Given this list of marker genes 4930599N23Rik, Trbv14, Gm2189, Mir490, Cnot4, Ptn, Tmem178b, Trbj2-6 (NCBI Gene Id 100125260), Trbv28, Gm15697, Trbv5, Mkrn1, Trbv12-1, Trbj2-5, Gm13861, Gm2719, 1700065J11Rik, Svopl, Gm25402, Fth-ps2, 1700111E14Rik, Trbj1-4, Trbv12-2, Zc3hav1l, Trbv13-1, Trbv21, Trbv26, Akr1d1, Rpl30-ps1, Braf, Hipk2, Bpgm, Gm29813, Try10, Tas2r108 (NCBI Gene Id 57253), Trbj1-3, Gm23010, Trim24, Trbv13-3, Mtpn, Gm2663, Clec5a, Gm18964, Ybx1-ps2, Rab19, Tmem213, Gm5409, Nup205, Cald1, Or9a4, Tas2r137, Trbv17, Slc37a3, Luc7l2 (NCBI Gene Id 75005), Tbxas1, Trbv11 (T cell receptor beta variable 11), Gm7452, Gm13858, Trbj1-7, Ssbp1, Klrg2, Gm4744, Fam180a, Trbj1-6, Trbv20, Wdr91, Trbv22, Creb3l2, Akr1b8, Stmp1, Trbv12-3, Trbj2-2, Atp6v0a4, Trbv4, Akr1b10, Trbd2, Trbv30, Trbv29, Gm13857, Prss3, Trbv8, D630045J12Rik, Prss2 (serine protease 2), Mrps33, Agk, Moxd2, Trbj1-2, Or9a7, Trbv18, Ubn2, Gm7463, Trbv15, Trbj2-4, Dgki, 1810009J06Rik, Prss1, Prss1l, Trbv27, Trbv25, 9330158H04Rik, Slc23a4, Trbv6, Ift56, Gm10244, Gm7554 (NCBI Gene Id 676634), Akr1b1, Trbv13-2, Trbc1, Trbj2-3, Trbv7, Clec2l, Fmc1, Npn2, Trbj1-5, Trbv9 (T cell receptor beta variable 9), Trbv31, Trbv16, Prss3l, Prss3b, Trbv3, Trbv19, Prss59, Gm7492, Wee2, Gm23273, Kdm7a, Stra8, 1700025N23Rik, Akr1b7, Mir7670, Trbv10, Trbj2-1, Trbd1, Trbv23, Gm23435, Slc13a4, Dennd11, Trbj2-7, Atp6v0c-ps2, Tas2r138, Trbv24, Parp12, Gm13864, Trbv1, Gm7556, Ndufb2, Dennd2a, Cyren, Mgam, Tmem140, Mgam2-ps, 8030453O22Rik, Trbv2, Trbc2, Chrm2, Gm13859, Gm26008, Gm43578, Trbj1-1, Prss58, Agbl3, Zc3hav1, Try5, Gm23231, Gm7504, Prss37, Try4, Adck2, Gm14546, here is a description of the gene set: species: Mus musculus Mouse Gene Set: chr6B1